Given this list of marker genes BCR (BCR activator of RhoGEF and GTPase), HLA-B, ERMARD, SMAD4, ALG9, TMTC3, PGM3, BUD23 (BUD23 rRNA methyltransferase and ribosome maturation factor), ATP6V1A, UBE4B, BGN, AEBP1, PLOD1, NKAP, ALDH1A2, MED12, MFAP5, RNASEH2B, SPTBN1, PKD1, ACTA2, CHD7, ROBO4, ALG5, APC2, NEDD4L, TMEM270, DNAJB11, RNASEH2C, LOX, IPO8, LMNA, RERE, SAMHD1, COL1A1, FLNB, COL5A1, LIMK1, CHST3, EFEMP2, TSC1, LYN, SMAD2, NSMCE2, ERCC6, KCNH1, MYH3, LUZP1, ATP6V1E1, NOTCH1, COL3A1, LSM11, RNASEH2A, HLA-DRB1, MYPN, TGFBR1, ABL1, PIGN, NSD1, IL12B, PRDM16, PPP1CB, ANGPTL6, RAI1, MID1, PTEN, TREX1, TPM2, MAPK1, PTPN22, SLC25A24, MAT2A, HGD, CHRNG, SKI, ADAMTS19, GTF2I, FMR1, IFT140, P4HA2, B3GALT6, MLX, SLC2A10, BICC1, THBS2, RIN2, MYLK, CRKL, SPECC1L, FKBP6, NOTCH3, ARFGEF2, ADAR, PKD2, THSD1, RFC2, NPR3, HSPG2, EIF4H, ZMPSTE24, TAB2, ELN, MAP1B, SEMA3E, TGFBR2, PDPN, CLIP2, DNMT3A, RNU7-1, ARF1, FLNA, STX1A, RAP1B, ZFX, B3GAT3, TSC2, CASZ1, TGFBR3, POLR1A, SMAD3, C12orf57, DPH5, PRKG1, TBL2, SMAD6, TGFB2, AFF4, TPM3, IFNG, FOXE3, FBN1, CARS1, DNAJC30, FBLN5 (fibulin 5), NOD2, GJA5, FBN2, GABRD, IFIH1, MMP23B, THSD4, BRF1 (BRF1 RNA polymerase III transcription initiation factor subunit), ATP2B1, GJA8, NODAL, HNRNPK, ERCC8, KCNAB2, SPEN, GTF2IRD2, COL1A2, GATA5, ALDH18A1, TNNT2, TGFB3, ENG, VPS37D (NCBI Gene Id 171020), MYH11, GTF2IRD1, PRKCZ, GANAB, BAZ1B, HEY2, TAF4, METTL27, FBXO11, NKX2-5, COL5A2, NCF1 (NCBI Gene Id 653844), KANSL1, here is a description of the gene set: studied in species Homo sapiens Aortic dilatation refers to a dimension that is greater than the 95th percentile for the normal person age, sex and body size. In contrast, an aneurysm is defined as a localized dilation of the aorta that is more than 150 percent of predicted (ratio of observed to expected diameter 1.5 or more). Aneurysm should be distinguished from ectasia, which represents a diffuse dilation of the aorta less than 50 percent of normal aorta diameter. Human Gene Set: HP_AORTIC_ANEURYSM Aortic aneurysm